The following is a description of a gene set: species: Homo sapiens Any process that increases the frequency, rate or extent of the regulated release of insulin that contributes to the response of a cell to glucose. Human Gene Set: GOBP_POSITIVE_REGULATION_OF_INSULIN_SECRETION_INVOLVED_IN_CELLULAR_RESPONSE_TO_GLUCOSE_STIMULUS, and this is the list of marker genes: PPP3CB, TRPA1, C1QTNF12, NADK (NAD kinase), NR1H4, HIF1A, PRKN, MPC2 (mitochondrial pyruvate carrier 2), ADCY8, TRPM5, SYBU, GPLD1, ANO1, DYNLL1, TUNAR, BAD, PHPT1, RFX6, SLC2A2, GPR27, ABCC8, OXCT1, GPRC6A, MLXIPL, GPR68, BAIAP3, PDX1, HLA-DRB1, GHRL, RAC1, GCG (glucagon), CFTR, TRPM4, STX4, OSBP, CRH, C2CD2L, PLA2G6, PPARD, VSNL1